Given this list of marker genes RPIA, GOT2, PGAM1, GLUD1, PGD, GAPDH, PSAT1, SDHB, ACLY, PPAT, DLST, TIGAR, TALDO1, PGK1, G6PD, ENO1, LDHA, GPI, SUCLG2, PAICS, PDHB, SLC16A3, IDH3A, ALDOB, GART, FASN, PFKL, PKM, GLS, PYCR2, PSPH, TKT, SLC1A5, SHMT2, FH (NCBI Gene Id 83748), HK3, MDH2, SLC2A1, IDH2, PDHA1, ACO2, PYCR1, here is a description of the gene set: Human Gene Set: WP_METABOLIC_REPROGRAMMING_IN_COLON_CANCER species: Homo sapiens Metabolic reprogramming in colon cancer